Given this list of marker genes PIP5K1B, VARS1, TSPAN4, CDC45, CHM, TPRKB, RIF1, DHRS3, RNPC3, HMBS, PSME3, PER1, PNO1, NDUFB4, RPL7L1, TNFSF11, HSD17B4, CCL2, CXCL14, ANP32E, CERS2, ALDH3B1, PCMT1, CASC3, SELENON, KLF4, BICD2, MTHFS, SNRPB2, SUOX, NFATC3, LYRM1, NUSAP1, ORMDL3, CROT, LYPLA1, TM9SF4, CEP20, PGAM1, TYROBP, TUSC3, ERBIN, STX7, DCK, ATP6V1C1, GABRR2, B3GALNT2, ZNF280D, NIT2, CYB5R4, PORCN, PLA2G4A, KCNA2, MTCH2, SYNPR, CDC16, MCFD2, MOB4, ORC4, ICAM5, VPS26B, GMPPA, FAM8A1, C1GALT1C1, FADS3, LYSMD3, TWF1 (NCBI Gene Id 82712), AVL9, CACNA1A, HLA-E, ACSL6, NDUFS3, RAB1A, ELAC1, VAV3, ESF1, PGRMC1, EFNB1, CDC25C, SLC35A1, CARD19, UBIAD1, ZNF574, BPNT1 (3'(2'), 5'-bisphosphate nucleotidase 1), SPEG, KICS2, ZNF600, HOXB1, AHCTF1, P2RY12, WDR75, HS2ST1, TTC1, KIF18A, RCAN1, UNC119, SEPTIN2, SMC6, SOS2, VSIR, CD300C, PRKCI (NCBI Gene Id 5584), MPC1, PRSS22, TPD52, INTS8 (integrator complex subunit 8), LAP3, MITD1, RBM7, PEX7, SCN4A, GBP6, AVPR1B, TMEM45B (transmembrane protein 45B), CCNG2, RWDD2B, CCNH, C2CD2L, EPHB4, RPS6KA3, RAB23, CFH, RDH11, RDH5, VSX2, RPS25, OSBPL11, PCCB, ASAH1, DTYMK, BRMS1, BCL2L13, PALS1, CCPG1, AP2S1, ZFHX4, DGKE, MRPL4, CRIPT, TEX264, ZNF227, MTSS1, NRBF2, GRK5, FASTKD5, NPY1R, NCBP3, SFXN2, MGLL, ACP5, ANKRD46, TIMP4 (NCBI Gene Id 7079), POLR2B, SERINC1, ACAT1, OCEL1, GCNT1, NABP1, MTMR6, CNNM2, TTC27, STAG2, SUN1, TGFBR1, RPAP3, RNF128, MRPS26, SLC37A3, RRP8, ZNF451, DRAM2, HPF1, TMEM106B, SFT2D1, EBAG9, SLC35C2 (NCBI Gene Id 51006), LYST, CYB5R1, POLE3, PENK, CNTN6, GREM1, FAM20B, MDM1, KCNJ12, ELP3, MED4, STARD4, MYOZ3, SHFL, FLI1, C6orf120, RNF166, CABP4, LCOR, RS1, HMGXB4, CUL3, TBC1D1, GTPBP3, here is a description of the gene set: Genes down-regulated in comparison of dendritic cells (DC) stimulated with poly(I:C) (TLR3 agonist) at 0.5 h versus DC cells stimulated with CpG DNA (TLR9 agonist) at 0.5 h. studied in species Homo sapiens from publication Amit I, Garber M, Chevrier N, Leite AP, Donner Y, Eisenhaure T, Guttman M, Grenier JK, Li W, Zuk O, Schubert LA, Birditt B, Shay T, Goren A, Zhang X, Smith Z, Deering R, McDonald RC, Cabili M, Bernstein BE, Rinn JL, Meissner A, Root DE, Hacohen N, Regev A (PMID 19729616) Human Gene Set: GSE17721_POLYIC_VS_CPG_0.5H_BMDC_DN mouse primary BMDCs were stimulated with tlr ligands and gene expression changes were profiled on Affymetrix arrays